Given this list of marker genes SV2C, SMKR1, FBXO33 (NCBI Gene Id 254170), ASAP2, AAK1, MRGBP, DCUN1D3, MGAM, LRIG3, ALKBH8 (alkB homolog 8, tRNA methyltransferase), KIF2A, CDYL2, USP6, DESI2, TLR2, PHTF2, EML5, LSM8, SLC25A4, DNAJC24, CNTNAP2, HOXB4, TRIM5, N4BP2L1, CDH11, TNFRSF25, DYNC1I1, C1orf198, SEC23A, ZBTB3, CUL3, RAB6B, AP3B2, MROH9, VPS13A, PTF1A, KCNN3, SIPA1L2, TNFSF14, AHSA2P, KLC1, ARID1A, DRAM2, PPP1R12A, here is a description of the gene set: Human Gene Set: MIR3126_3P Genes predicted to be targets of miRBase v22 microRNA hsa-miR-3126-3p in miRDB v6.0 with MirTarget v4 prediction scores > 80 (high confidence targets). from publication Chen Y, Wang X (PMID 31504780) species: Homo sapiens